Given this list of marker genes PIK3CA, BCL7B, THPO, GOLPH3L, TRIP6, TMEM222, POLDIP3, GNA15, SMC3, FOXN2, LDHA, TUT7, DDX1, NOL7, PROX1, AURKB, LGALS3BP (galectin 3 binding protein), GNG4, PTGR1, FAS, PLK1, ACHE, ARGLU1, TTC1, TMEM38B, GJD2, BRCA1, RAMP1 (NCBI Gene Id 10267), RYR1, PABPC4, MAP7D1, POLR2D, KLF6, TBL1XR1, PIK3C2A, RNASEK, GOLGA7, GADD45B, BLVRA, CAMLG, RPS25, CAPN9, FARSB, RCN1, ANXA1, ELF3, COL4A1, RAN, ZNF821, ACIN1, TP53, HIP1R (NCBI Gene Id 9026), ZNF347, ETS2, CCL5, IGLC7, AMBRA1, NFYB, EIF2B4, ABCA1, KCNK3, SPP1, RIC8A, NUDT21, LTV1, PUF60, ICAM1, NAA15, DDX49, CIC, SPIN1, PLAC8, ZC3HC1, PRDM1, SLC16A1, NDE1, SMN1, LAPTM4A, FAAP20, SERPINA3, MYH1 (myosin heavy chain 1), EIF4A3, JUND, EFHD2, LBP, SRRT, APCS, HRAS, MX1, AZI2, GABARAP, ACTN1, DDB1, SCOC, FOXA3, UBE2J2, SUGT1, HSD11B2 (hydroxysteroid 11-beta dehydrogenase 2), POLR1B, NEK7, MRPL30, SDHAF2, FZD2, RHOB, SCX, EZR, CHMP4B, SSRP1, ID3, TWF2, CRTAM, CPNE3, PDIA5, AFG2A, TAB3, HSD17B12, LTBR, CLDN7 (claudin 7), NARS1, NEK6, USP18, AQR, RAB4A, VNN1, FGD1, PPID, TGFB1, S100A6, OMP, SLC6A6, CEBPZ, DNAAF10, ADGRB1, ARPC1B, CTPS2, LYVE1, RAB28, ATF4, CPSF2, EIF3K, VPS72, ZCCHC10, LCN2 (lipocalin 2), MAPRE1, CFDP1, HPX, CDC45, ITIH3, TMEM62, MT2A, CCDC115, NPNT, CRIP2, SRPRA, AIMP1, UBE2A, SRSF6, CCT6A, METTL18, EIF3J, SCEL, ALYREF, GNL2, RHOD, SMU1, GAS6, ART3, NVL, AKAP8, OSMR, ORM2, COPB2, GGPS1, SMAD1, CAPN1, SLC10A6, CSTF2T, PLEC, CIAO2B, ZBTB17, WDR43, VBP1 (NCBI Gene Id 7411), IBTK, ESR1, NUB1, RAB1A, GDAP2, LY6E, ITIH4, CYB561, ICE1, WDR20, UBE2L6, PTPRK, ARF6, IL1RN, GNAT1, GALNT2, PHTF1 (putative homeodomain transcription factor 1), SRSF3, here is a description of the gene set: from publication Ramirez K, Chandler KJ, Spaulding C, Zandi S, Sigvardsson M, Graves BJ, Kee BL (PMID 22608498) species: Homo sapiens Genes down-regulated in multipotent progenitors versus RAG2 knockout NK cells. Expression profiling of Rag2-deficient Ets1++ and Rag2-deficient Ets1-- mature NK cells and WT bone marrow progenitors, WT T cells, and WT Pro B cells Human Gene Set: GSE37301_MULTIPOTENT_PROGENITOR_VS_RAG2_KO_NK_CELL_DN